The following is a description of a gene set: Remodeling the acyl chains of phosphatidylglycerol, through sequential deacylation and re-acylation reactions, to generate phosphatidylglycerol containing different types of fatty acid acyl chains. species: Homo sapiens Human Gene Set: GOBP_PHOSPHATIDYLGLYCEROL_ACYL_CHAIN_REMODELING, and this is the list of marker genes: LPCAT1, PLA2G4D, PLA2G4F, PLA2G2F, PLA2G4B, CRLS1, LPCAT4, SERAC1, LPGAT1